The following is a description of a gene set: An assembly of four or five subunits which form a structure with an extracellular N-terminus and a large loop that together form the ligand binding domain. The C-terminus is intracellular. The ionotropic glutamate receptor complex itself acts as a ligand gated ion channel; on binding glutamate, charged ions pass through a channel in the center of the receptor complex. NMDA receptors are composed of assemblies of NR1 subunits (Figure 3) and NR2 subunits, which can be one of four separate gene products (NR2A-D). Expression of both subunits are required to form functional channels. The glutamate binding domain is formed at the junction of NR1 and NR2 subunits. NMDA receptors are permeable to calcium ions as well as being permeable to other ions. Thus NMDA receptor activation leads to a calcium influx into the post-synaptic cells, a signal thought to be crucial for the induction of NMDA-receptor dependent LTP and LTD. species: Mus musculus Mouse Gene Set: GOCC_NMDA_SELECTIVE_GLUTAMATE_RECEPTOR_COMPLEX, and this is the list of marker genes: Ptk2b, Grin2a, Grin1, Grin2b, Eps8, Grin3b, Grin2d, Grin2c (glutamate receptor, ionotropic, NMDA2C (epsilon 3)), Grin3a